Given this list of marker genes Bptf, Rab43 (RAB43, member RAS oncogene family), Zfp329, Xylt2, Amd2, Tab2, H2-M5, 4930555G01Rik, Stk35, Ormdl3, Gm3500, Dab1, Pdxp, Ubn2 (ubinuclein 2), Wars2, Shank3, Aff1, Igdcc3, Ebf2, Gm3558, Ciao1, Nr6a1, Sim1, Smarcd1, Apln, Nectin1, Eya1, Manba, Scaf4, Trpc4, Map1lc3b, Arrb1, Dgkg, Gas7 (NCBI Gene Id 320013), Cplx3, Ammecr1l, Zdbf2, Rhoa, Stxbp1, Ube3d, Gpm6b, Armc9, Ptprf (protein tyrosine phosphatase receptor type F), Myo9a, Pip4k2a, Rims2, Arf5, Gm10406, Ankrd33b, Tnfaip1, Zfp616, Idh3b, Akirin1, Eml6, Tmc7 (transmembrane channel-like gene family 7), Acer2, Gcnt7, Zscan21, 4930523C07Rik, Gml, Sox7, Scai, Ldlrad4, H2ab3, Wars1, Chmp6, Fkbp5, Banp, Dab2ip, Rusf1, Inpp5a, Gml2, Pard3b, Maip1, Tsc1, Rora, Zfp131, Ppil2, Mab21l1, Casp2, Gm2897, Cdc40, Ccdc73, Gpr39 (G protein-coupled receptor 39), Gpr17, Sh3pxd2b, Ralgps2, Slc24a2, Me3, Carhsp1, Ramp2, Gm3696, Zfp746, Galnt9, Irx2, Gm3411, Stox2, Mtres1, Samd4, Marcks, Tbc1d22a, Atat1, Tcf7, Gnaq, Ppp2r5d, Ywhaz, Diaph2, Lrrc4b, Sfxn4 (sideroflexin 4), Zfp128, Nkain1, Pdxk, En1, here is a description of the gene set: Genes predicted to be targets of miRBase v22 microRNA mmu_miR_12194_3p in miRDB v6.0 with MirTarget v4 prediction scores > 80 (high confidence targets). Mouse Gene Set: MIR_12194_3P species: Mus musculus from publication Chen Y, Wang X (PMID 31504780)